The following is a description of a gene set: Systems vaccinology has emerged as an interdisciplinary field that combines systems wide measurements and network and predictive modeling applied to vaccinology. Here we used the systems vaccinology approach to study the molecular mechanisms underlying th Genes up-regulated in comparison of B cells from influenza vaccinee at day 7 post-vaccination versus myeloid dendritic cells (mDC) at day 7 post-vaccination. from publication Nakaya HI, Wrammert J, Lee EK, Racioppi L, Marie-Kunze S, Haining WN, Means AR, Kasturi SP, Khan N, Li GM, McCausland M, Kanchan V, Kokko KE, Li S, Elbein R, Mehta AK, Aderem A, Subbarao K, Ahmed R, Pulendran B (PMID 21743478) Human Gene Set: GSE29618_BCELL_VS_MDC_DAY7_FLU_VACCINE_UP studied in species Homo sapiens, and this is the list of marker genes: WDR11, PCDH9, ANKRD36, SPRY1, RASGRP2, PIK3IP1, ETS1, TSPYL1, ZBED5, IGHG1, PLEKHA2, AEBP1, SMAGP, IGKV4-1, FCMR, FCHSD2, CXCR5, MYC, BACH2, TTC9, PAX5, EIF4A2, TNFRSF13B, CDC37L1, OGA, ABLIM1 (NCBI Gene Id 3983), NT5E, TRAF5, ADD2 (NCBI Gene Id 130935), ADD3 (adducin 3), POU2AF1 (NCBI Gene Id 5450), TCF4, TCF3, PPP1R16B (protein phosphatase 1 regulatory subunit 16B), PRKD2, SP140, GGA2, SEL1L3, CD24 (NCBI Gene Id 934), EIF2AK3, CD81, BTG1, EHD1, ZNF24, AQP3, SWAP70, RASGRP3, ZNF395, ZNF253, IGKC, IL4R, ATP2A3, STAG3, ODC1, CDK5R1, CHD7, CD69, FCRL2, CTC1, PKIG, MZB1, ARHGAP24, TRBC1, TPD52, VPREB3, MS4A1, CD79B, SKAP1, KMO, FUT8, RBBP6, CD79A (CD79a molecule), CEMIP2, TAF7, NCK2, RNF141, WASF1, ITM2A, P2RY10, PRDM2, PIKFYVE, ISCA1, ADAM19, KIAA0040 (KIAA0040), SPOCK2, TSC2, IGHM, ATF7IP, CD19, LAMC1, CD22, EIF1B, ARHGEF18, BMS1P20, IGKV1D-13, SP100, CD83, IGLL3P, CDC25B, SETBP1, PLCG2, ST6GAL1, PDCD4, CYFIP2, ZMYND8, VPS13A, PDLIM1, TCL1A, IL24, CSGALNACT1, ATAD5, EAF2, PLEKHF2, GOLGA2P5, RHOH, PCF11, FAM3C, TERF2IP, SMCHD1, CR1, IGLJ3, ADAM28, FCER2, CD37, OSBPL10, SIPA1L1, CLEC2D, PRKCB, SEC62, PELI1, PIP5K1B, IKZF3, BACE2, DGKD, KCNA3 (NCBI Gene Id 3738), BANK1, SMC6, ARID4B, GUSBP11, PTPRK, P2RX5 (NCBI Gene Id 5026), LINC00216, S1PR1, BLK, PKIA, SYPL1, SNX2, PAWR, IGKV3-20, CD200, GON4L, LTB, CKAP2, KAT6A, CDK14, SP110, SYNPO, STAP1, LBH, STK17A, COBLL1 (NCBI Gene Id 22837), DDX6, ZNF273, JCHAIN, SHOC2, CD47, FAM30A, RASGRP1, CHMP7, TAF1D, ZNF43, PTPRCAP, PHTF2, PNOC, PIK3C2B, NUP88, MAP4K4, SPON1, SPTBN1, IFT57, MXI1, ARID5B, PIM2, EZR, IGLV1-44, RUBCNL, MBD4, RRAS2, ZNF665, GPR18, DUS2, BIRC3, SRSF10